Given this list of marker genes MKI67, TACC3, HNRNPDL, TUBB, CENPM, SIVA1, KIF15 (kinesin family member 15), NUCKS1, CMTM8, E2F7, HASPIN (NCBI Gene Id 83903), SLC7A3, KIF11, SKA3, GCSAM, MND1, H2BC18, SUMO2, DCTN3, CDC25C, MAGOH, H2AC12, USP1, BIRC5, CAMK2D, PSRC1, NPPC (natriuretic peptide C), MAD2L1, SSBP2, TRAIP, PIF1, ACADM, H2AX, CDK5RAP2, HMCES, CDCA5, SGO1, BUB3, LIG1, ACOT7, PARP1, HIRIP3, INCENP, PRPSAP1, HNRNPU, HNRNPA0, TLCD3B, EZH2, CKAP2L, PSIP1, NONO, CCND3, IFT22, TIFA, MARCKSL1, CD72, CENPA, HAUS1, E2F2, ASPM, CEP55, AMOTL1, HJURP, ENSG00000224905, PHGDH, FIRRM, EPB41L2, BIK, SMC1A, TMPO, HMGN3, H2AC14, DEK (NCBI Gene Id 7913), NUDT5, ITGAE, NRM, PIN1, FANCG, SAE1, HERC5, CDCA7, MACROH2A1, C12orf57, NDC80, CBX1 (NCBI Gene Id 10951), PAIP2, PRR11, NUSAP1, RPRML, ATP2A3, PIM1, PPIA, MDH1, ANP32E, CSRP2, FAIM, LMNB1, PSMB8, HNRNPA3, ENSG00000187951, RAD21, FOXM1, AKR1B1, CCNF, SYVN1, GGH, IMMP1L, H2AC17, FBXO43, SPTBN1, BAHCC1, TIMELESS, KIFC1, HMGN1, KPNA2, SMARCA4, TCF19, CARHSP1, ACP1 (acid phosphatase 1), HNRNPA2B1, TPX2, SRSF9, CTPS1, HNRNPA1, SRP14, SHCBP1, SKP2, CLSPN, HNRNPK, SPC25, TOP2A, NUF2, H2AZ1, PAQR4, ATAD2, HMGB3, RPL39L, DRAXIN, NUDT21, UBE2C, UBE2E3, NCAPD2, RACGAP1, PXMP2, ARHGAP33, H3-3A, RALY, EIF4A3, ALDH7A1, ASF1B, CTCF, CENPN, PSMC3IP, CTNNBL1, MFGE8, GDI2, PPP1CA, H2AC20, NCAPH2, TYMS, TMSB15A (NCBI Gene Id 11013), TERF1, PDLIM1, MED30, H3C8, MID1IP1, TMEM106C, EWSR1, ATP5F1C (NCBI Gene Id 511), CEP70, CDKN2C, TP53I13, N4BP2, SERHL2, HNRNPH3, QPRT, KIF14, MYO3A, TCF3, SMARCB1, C21orf58, NDUFA4, ANP32A, UBE2S (ubiquitin conjugating enzyme E2 S), N4BP3, DDX39A, H2BC7, H2BC9, CD47, HAUS8, H4C3, CCNE2, SRP9, KNL1, APBB1IP, PHF19, CCDC167, KPNB1, ARL6IP1, MIS18BP1, ITGB3BP, IKZF2, STMN1, HELLS, FAM111A, SKA2, STRBP, VDAC1, RAD51AP1, KHDRBS1, H2AC16, CDCA7L, RBM8A, FUS, DYNLT2B, SRSF10, CIP2A, CKS1B, UBE2I, RNASEH2B, DDAH2, WDR62, EIF4G2, IFT25, SMC4, UBB, DCLRE1C, CBX5, POU2AF1, TMPO-AS1, RBBP7, IGLL1, CDKN2A (NCBI Gene Id 1029), MZT1, SMARCE1, TFDP2, DERA, HNRNPH1, TXNDC12, CENPF, FBXO5, CCNI, LAT2, YWHAQ, HP1BP3, MXD3, HNRNPR, ACTG1, RMI2, SAC3D1, HMGN2, GLO1, TTC7A, CCP110 (centriolar coiled-coil protein 110), CDCA8, MAPRE1, SRSF3, GALNT14, TUBA1B, RDM1 (NCBI Gene Id 201299), DLEU2, FAM111B, WDR76, CD24, IGLC5, SFPQ, KHDRBS3, H2BC15, H2AZ2, MSI2, MAD2L2, PPP1CC, TMEM263, SF3B2, PIMREG, NSD2, E2F8, DCK, BARD1, HNRNPM, MYL6B, E2F1, TRA2B, SLC25A5, NTAN1, GTSE1, TIAM1-AS1, PTMA, SET, ACAT2, HMGB2, APOLD1, RBBP8, RTKN2, HMGB1, ZNF704, ZWINT, RBMX, CRNDE, SGO2, UGP2, EAF2, RAD51, AURKB, H1-5, here is a description of the gene set: from publication Hay SB, Ferchen K, Chetal K, Grimes HL, Salomonis N (PMID 30243574) Human Gene Set: HAY_BONE_MARROW_PRO_B species: Homo sapiens